Given this list of marker genes SMARCB1, GDF5, TFAP2B, PUM1, DVL1, NIN, IFT140, PUF60 (poly(U) binding splicing factor 60), BMPR1B, SRCAP, BMP2, RUNX2, WNT5A, RBBP8, GNB2, ERF, ERI1, BHLHA9, RAI1, ROR2, IGF2, KIF15, COL2A1, HOXD13, ARID1B, TBX5, NOG (NCBI Gene Id 9241), HNRNPR (heterogeneous nuclear ribonucleoprotein R), MYCN, ATP6V1B2, GJA1, here is a description of the gene set: Aplasia/Hypoplasia of the phalanges of the 5th finger studied in species Homo sapiens Aplasia/Hypoplasia of the phalanges of the 5th finger. Human Gene Set: HP_APLASIA_HYPOPLASIA_OF_THE_PHALANGES_OF_THE_5TH_FINGER